The following is a description of a gene set: Neovascularization processes Human Gene Set: WP_NEOVASCULARIZATION_PROCESSES studied in species Homo sapiens, and this is the list of marker genes: SMAD9, TGFB3, TGFB1, DLL4, EPHB2, NFKB1, ANGPT1 (angiopoietin 1), SMAD1, SMAD5, MMP9, MAPK9, NFKB2, MAPK8, SMAD2, CXCL12, HIF1A, RELA, TGFB2, MAPK3, AKT1, EPHB4, MAPK1, PDGFB, NOTCH4, KITLG, JAG1, FLT4, SMAD3, NOTCH3, CXCR4, NOTCH1, KDR, TGFBR1, REL, ACVRL1, KIT, RELB